Given this list of marker genes PLCG1, CCND1, PLCG2, ARAF, MAP2K1, PRKCB, MAPK1, MAPK3, PRKCG, ALK, RAF1 (NCBI Gene Id 5894), MAP2K2, BRAF, PRKCA, here is a description of the gene set: Pathway Definition from KEGG: EML4-ALK -> PLCG -> IP3 -> (Ca2+,DAG) -> PKC -> RAF -> MEK -> ERK -> CCND1 Human Gene Set: KEGG_MEDICUS_VARIANT_EML4_ALK_FUSION_KINASE_TO_PLCG_ERK_SIGNALING_PATHWAY species: Homo sapiens EML4-ALK fusion kinase to PLCG-ERK signaling pathway. Pathway ID: N00025. Pathway type: Variant. Pathway class: nt06266 Non-small cell lung cancer.